Given this list of marker genes SLC6A8 (solute carrier family 6 member 8), IFT43, CHST14 (carbohydrate sulfotransferase 14), NSD1, HRAS, ALG8, C1S, FGD1, ATP6V1E1, TWIST2, CDK13, EXT1, RPS6KA3, RTL1 (NCBI Gene Id 651665), FKBP14, LTBP4, HPGD, ADAMTSL2, GNB2, CD96, SMARCA2, WDR35, EFEMP1, CFTR, MLXIPL, ADAMTS2, COG7, SON, ATP7A, WDR37, PRDM5, PTEN, RAD21, COL5A2, RTEL1, TINF2, H1-4, SUZ12, PTPN11, C1R, SPINT2, SLC39A13, METTL27, FBLN5, PDGFRB, LZTR1, MAP2K1, CEP55, ANTXR1, COL12A1, EIF4H, MAP2K2, DSE, ACD, FGF20, COL1A2, SLC25A24, NCF1, RIN2, ATP6AP2, MRAS, MRPS16, KIAA0586, SMARCD2, KRAS, XYLT1, NPR2, NDUFB10 (NCBI Gene Id 4716), GTF2IRD2, NAA10, TRPS1, NEPRO, MAN1B1, PITX2, COL3A1, PRMT7, TBL2, GORAB, TMEM270, VAC14, THBS2, SEPTIN9, COL1A1, PIK3R1, PLOD1, MRPS22, IPO8, FIG4, CSPP1, ABCC6, OTUD5, PYCR1 (pyrroline-5-carboxylate reductase 1), TGM5, ALG12, FBN1, FGFR2 (fibroblast growth factor receptor 2), SLC26A2 (NCBI Gene Id 1836), SHOC2, VPS37D, DLK1, B4GALT7, KMT2C, AARS1, GSN, RFC2, STX1A, GBA1, ENPP1, CLIP2, WDR19, WDR81, ALDH18A1, CSTA, SLC2A10 (solute carrier family 2 member 10), LTBP1, PUF60, YY1, WLS, AEBP1, PEX1, ASXL1, RAF1, H4C5, GGCX, PTDSS1, XYLT2, TRAF7, ELN, BRAF (B-Raf proto-oncogene, serine/threonine kinase), BUD23, NBAS, TBL1XR1, ATP6AP1, TERT, GTF2IRD1 (GTF2I repeat domain containing 1), DKC1, BAZ1B, COL5A1, SKI (NCBI Gene Id 6497), FOXC1, INSR, TBX15, DNAJC30, SH3PXD2B, ATP6V1A, AKT3, EFEMP2, SRD5A3, TGFB2, FLNA, PARN (poly(A)-specific ribonuclease, NCBI Gene Id 5073), GPX4, MEG3, ATP6V0A2, NDUFB11 (NADH:ubiquinone oxidoreductase subunit B11), EBP, EHMT1, CHST3, LIMK1, B3GAT3, PIGA, FKBP6, IFT140, IARS1, MEGF8, B3GALT6, TUBB, B4GALT1, EZH2, TNXB, GTF2I, SLC7A7, PAX2, FGFR3, ZNF469, BCL11B, RIT1, MAPRE2, here is a description of the gene set: studied in species Homo sapiens Human Gene Set: HP_ABNORMALLY_LAX_OR_HYPEREXTENSIBLE_SKIN Abnormally lax or hyperextensible skin